The following is a description of a gene set: Human Gene Set: GCM_CALM1 studied in species Homo sapiens Neighborhood of CALM1 Neighborhood of CALM1 calmodulin 1 (phosphorylase kinase, delta) in the GCM expression compendium, and this is the list of marker genes: LARGE1, VPS26B, TTL, DYNC1I2, SPIRE1, KDM3B, TSPYL4 (TSPY like 4), PNMA8A, SLC8A2, RMDN3, RAN, NDFIP1, UBE2K, NISCH, ADO (NCBI Gene Id 84890), GBA2, MCF2L, TRIM37, HERC2, ZNF84, NUAK1, CORO2B, FOXO3, ABI2, MAPK8IP3, PJA2, NGRN, ZER1, GSK3B, ACTRT1, BMPR2, CRKL, RERE, MTMR4, RALGAPB, PREPL, ATP6V1B2, ASAP2, CCDC92, SELENOI, EXOSC6, GPR107, STMN3, VPS52, ACSL3, FBXO21, APC2, TMEM30A, DYNC1H1, FAM168B, KIF3B, DUSP26 (dual specificity phosphatase 26), DDX17, XPO6, USP33, MAP1B, TAF9B, KIF5C, PDXP, RTN4, CLEC16A (C-type lectin domain containing 16A), MAP6, RNF41, PHF2, DDAH1, POGK, CALM1, NCAM1, WSB2, GPRASP2, GSTA4 (NCBI Gene Id 2941), FAM219A, SIK3, KIDINS220, IDS, MAPK8IP1 (NCBI Gene Id 9479), CAND1, PPME1, LANCL1, ZNF275, NUP133, YWHAG, TCHP, BTRC, SNX27 (sorting nexin 27), CLIP3, NAPG, ANKRD17, POGZ, TNPO2, USP19 (NCBI Gene Id 10869), NCKAP1, KIF1B (NCBI Gene Id 57598), NAA30, RALGAPA1, STX12, MOAP1, MRTFB, CLASP2, SCAMP5, WBP2, CLCN3, PRXL2A, CHST10, FBXW11, CSRNP2, MAP4K4, APPBP2, SESN3, EIF4ENIF1